The following is a description of a gene set: species: Mus musculus The process in which the branching structure of the mammary gland duct is generated and organized as a part of pregnancy. Mouse Gene Set: GOBP_MAMMARY_GLAND_BRANCHING_INVOLVED_IN_PREGNANCY, and this is the list of marker genes: Pgr, Med1, Ar, Wnt4 (NCBI Gene Id 22417), Esr1, Vdr, Csmd1